The following is a description of a gene set: studied in species Mus musculus The cell fate determination process in which a cell becomes capable of differentiating autonomously into a mesoderm cell in an environment that is neutral with respect to the developmental pathway; upon specification, the cell fate can be reversed. Mouse Gene Set: GOBP_MESODERMAL_CELL_FATE_SPECIFICATION, and this is the list of marker genes: Six2, Pax2, Dkk1, Nodal, Tbx6, Mesp1, Bmpr1a, Etv2, Eya1, Sfrp2, Fgfr1, Wnt3a, Hoxa11